The following is a description of a gene set: species: Mus musculus Mouse Gene Set: chr10C1, and this is the list of marker genes: Tjp3 (NCBI Gene Id 27375), Gm18119, Adat3, Dram1, Gm8170, Gipc3, Gm21026, Slc39a3, Oaz1 (NCBI Gene Id 18245, ornithine decarboxylase antizyme 1), Gm26402, Krtap10-30, Bpifc, 4930442H23Rik, Fhl4, 1700009J07Rik, Pdxk, Vmn2r81 (NCBI Gene Id 394231), Gm16315, Adora2a (adenosine A2a receptor), Ilvbl, Diras1, Or7a39, Zfp781b, Gm35920, Gm26357, Sirt6, Pcsk4, Csnk1g2, Or7a36, Gm8112, Tyms-ps, Mcm3ap, Krtap12-24, Gadd45b (growth arrest and DNA-damage-inducible 45 beta), Sf3a2, Pwp1, Gm35608, Zfp280b, Gm6714, Gm15608, Adarb1, Rps15, Psma5-ps, Bcr, Pwwp3a, Gm48551, Syn3, Misp, 4921515L22Rik, Txnrd1, Tektip1, Gamt, Gm5779, Snrpd3, Casp14, Gm19688, Krtap10-32, Med16, Zfp433, Sppl2b, Dnmt3l, Lrrc3, Mir6409, Mir6908, Ptbp1, Krtap10-34, Mir6910, Gm17980, Krtap10-10, Gm8290, Gm6713, Atcay (ataxia, cerebellar, Cayman type), Ndufs7, Tmem263, 4930486F22Rik, Gm30400, Btbd2, Grin3b, BC025920, Fzr1, Pcbp3, Cry1, Gm10778, Or1i2, Abca7, 4930555G07Rik, Gm40723, Gnptab, Krtap12-1, Hcn2, Adamtsl5, Or10b1, Cbarp, 4933436P19Rik, Gm34184, Gm8137, Gm6729, Specc1l, Plekhj1, 1700092E16Rik, Celf5, Dip2a, Spic, Eid3, Ggt1, Or7a38, C2cd4c, Timp3, Cfd, Cactin, Tektl1, Gm10787, Trpm2, Ric8b, Ckap4, Cabin1, Gucd1, Gm35721, Mir3057, Gm2628, Cirbp, Fgf22, Gna11, Pip5k1c, Pcnt, Mir678, Gm16221, 2610008E11Rik, Gm16099, Gm25794, Parpbp, Gm10764, Spmap2, Tcf3, Aldh1l2, Gm8274, Derl3, Fam174c, Gm4767, Fabp3-ps1, Elane, Tle5, Gm5174, Col18a1, Krtap12-22, Or7a37, Cdc34, Gstt2, Mknk2, Or7c70, Apc2, Rrp1, Ascl1, Gm19989, Lrrc75b, Fstl3, Trappc10, Atp5f1d, Nopchap1, Krtap10-22, Gm8435, Gm7775, Gm5173, Creb3l3, Glt8d2, Mir6909, Spata31h1, Krtap10-23, Krtap10-4, Nmrk2, Gm19186, Mir6912, Agpat3, Krtap12-20, Gm1559, Krtap10-33, Gm10773, Krtap12-23, 1700028I16Rik (NCBI Gene Id 70003), Mir1191b, Rnf126, Ggt5, Slc19a1, E230014E18Rik, Vmn2r83, Washc4, Matk, Krtap10-29, Kiss1r, Pfkl, Hsp90b1, Jsrp1, Gm7842, Gm10777, Itgb2, Gm5951, Stk11, Ncln, Sgta, Mfsd12, Gm1553, Gm6721, Gm19624, Mir6911, Hcfc2, Mterf2, Gm19612, Ap3d1, Gm21027, Gm49918, Dohh, Chst11, Gm15122, Prdm4, Palm, Lingo3, Mier2 (NCBI Gene Id 70427), Timm13 (translocase of inner mitochondrial membrane 13), Nt5dc3, Pttg1ip, Chpt1, Mir6907, Dot1l, Gm47944, Pah, Prmt2, 1700113H08Rik, Plk5, Gm3828, Mrpl54, 4921516A02Rik, Krtap10-31, Gm9583, Rab36, Gm34113 (predicted gene, 34113), Gm40692, Cnn2, Lss, Slc41a2 (NCBI Gene Id 338365), Upb1, Gatd3a, Gm18876, Polrmt (polymerase (RNA) mitochondrial (DNA directed)), Gm46192, Dapk3, Gm16104, Gm48160, Rtcb, Gm22871, Gm38575, Chchd10, Gstt4, Pias4, C230099D08Rik, Izumo4, Pmch, Mybpc1 (NCBI Gene Id 77491), Nuak1, Gm19810, Krtap10-27, 4930463O16Rik, Vmn2r82, Krtap12-21, Tcp11l2, Zfr2, 2610034O05Rik, Reep6, Mbd3, Efna2, Gm24430, Gm38560, Icosl, Sbno2, Krtap10-28, Gpx4, Slx9, Gm17249, Tmprss9, Gstt3, Pofut2, 1500009L16Rik (RIKEN cDNA 1500009L16 gene), Gm47922, Or7a41, Pwp2, Gm867, Gm46194, Thop1, Shc2, Gm19217, Gm5134, Zbtb7a, E130317F20Rik, Susd2, Zfp873, Igf1, Abtb3, Slc5a4b, Amh, Gm16271, Mob3a, Gm46191, Cstb (NCBI Gene Id 13014), Tpgs1, Smim24, Midn, Prss57, Gm32687, Nfic, Gm8249, AU041133, Gm5425, Tbxa2r, 1700025N21Rik, Vmn2r-ps92, Gm48106, Gm15343, Tdg, Gm30232, Ap3m1-ps, Apba3, A230060F14Rik, Spatc1l, Atcayos, Mir1930, Ascl4, Krtap10-35, Bsg, Gzmm, Prtn3, Tle6, Gm4925, Gm8188, Arl1, Washc3, Polr2e, Gm3137, Gnaz, Gm30346, Mif, Stab2, Rsph14, Ttc41, 2310011J03Rik, Gm48175, Gm6653, Hmg20b, Gm9466, Gm25657, Tspear, Sycp3, Mir7659, Madcam1, Cfap410, Or7a42, Ube2g2, Tle2, Gm30122 (predicted gene, 30122), Gm29807, Lmnb2, Gm22394, Vpreb3, Gm3055, Slc5a4a, Mmp11, 1810014B01Rik (NCBI Gene Id 66263), Utp20, Gm8153, Gm8264, Igf1os, Gm9978, Mir5615-1, Gm8158, Dazap1, Gm10941, Gm40709, Rexo1, Mex3d, 2610028H24Rik, Gstt1, Krtap10-24, Gm48552, Col6a2, S1pr4, Zfp938, Gm16269, Gm47459, Lsm7, Snord37, Gm4924, Ftcd, Eef2, Map2k2, Syde1, Uqcc6, BC024063, Klf16, Rfx4, Scamp4, Onecut3, Gng7 (NCBI Gene Id 14708), Gm4799, Fbxo7, Ankrd24, Ddt, Krtap10-26 (keratin associated protein 10-26), Mir6410, Appl2, Col6a1, Plppr3, Gm18556, Gm18251, Nfyb, Plpp2, Krtap10-21, Slc5a8, Tmem259, Gm16270, Arhgap45, Platr7, Sumo3, Krtap10-25, 1700094J05Rik, Gm10146, Smarcb1, Gm16222, Gm19326, Gm46234, Mir5615-2, Polr3b, Ybey, Gm16219, Aire, Vmn2r80, Mir6913, Wdr18, Atp8b3, Arid3a, Nup37, Uqcr11, R3hdm4, Gna15, Or7a35, Cimap1d, Abhd17a, Slc1a6, Mir1982, S100b